Given this list of marker genes PIWIL1, ALOX12, ZFP62, DNAJC17, CSNK1A1, CLCF1, GTPBP2, CYP3A7, F10, NUP133, MAPK9, TMOD3, MITF, NINJ1, STRN3, GAB3, SSBP3, UNC93B1, PRPF38A, GOLPH3L (golgi phosphoprotein 3 like), WASHC1, UQCR10, EDN1, PHB1, ZNF22, SQSTM1, YTHDF2, COX6C, UBA7, MAP3K8, CCL2, POP7, FABP3, FCGR3A, SUGT1, RPL7L1, PDCD5, SNTG2, SYTL1, PA2G4, ACTR6, CHRD, GTF2B, MED6, ADAMTS4, C18orf21, CSPP1, LAP3, COPS6, MCCC2, NRROS, FTSJ3, NIPA2, CCT6A, CPOX, APOBEC1, CARS1, RRAS2, NECTIN3, CRISP2, COG8 (NCBI Gene Id 84342), RBMX, BUD31, ACADL, BLOC1S6 (NCBI Gene Id 26258), NMNAT1, C2CD2L, ITM2A, DIRAS1, UQCRFS1, CIDEA, CLP1, ASNS, MRPL49, GLRX3, PPIL2, DUOXA2, FBXO22, RGS2, FASTKD2, GHITM, SGCB (sarcoglycan beta, NCBI Gene Id 6443), CD81, DHX36, STK4, IL12B, TRAPPC5, RBBP7 (RB binding protein 7, chromatin remodeling factor), SERPINB9, BLOC1S4, HDAC3, CA13, TMEM60, CYTH3, PLCZ1, IL10RA, GADD45B, SLCO3A1, ARGLU1, DNAJC13, ERAP1, MAGI1, TINAG, ATF4, SPTA1, AMN, HTRA1, DUSP2, SBDS, ASB3, RIF1, RGS1, TSPYL1, DBNL, IL10RB, LPO, SPIC, LZTFL1, GTF2F2, CHRNA5, PYCARD, CXCL10, MRPL51 (NCBI Gene Id 51258), LSM10, HMX1, UCP2, CRIM1, SERPINC1, REEP3, SUOX, HDC, KDM5C, OGFR, RWDD4, ZNF24, RPS25, RBMXL1, DDX54, RASL12, ARHGAP17, ZNF334, PACRGL, RAP2C, CELF1, IL2RA, ELOC, ENDOD1, KYAT3 (kynurenine aminotransferase 3), POLH, C19orf25, SLFN12, DYNC1LI1, TLR1, LAD1, CHID1, NDUFV1, GLA, KPNA2, METRNL, CFAP36, NDUFS8, ASB13, EIF2B5, KCTD4, DENND2B, IL15RA, TPD52L2, RMDN3 (NCBI Gene Id 55177), TMEM219, GPATCH2, CD300LF, AKT3, RREB1, SUV39H1, IDNK, RNASE4, TBK1 (TANK binding kinase 1), SFXN2, MTMR2, DTNBP1, ALCAM, C5AR1, IGBP1, CNTN6, APTX, AKR1B1, POLE2, NPHS1 (NCBI Gene Id 8183), LHX6, PURB, BRWD3, HMGB1, CRYBB1, NCK2, NAT2, VRK2, CHAC2, PLIN3, CBLN3, here is a description of the gene set: Human Gene Set: GSE17721_CPG_VS_GARDIQUIMOD_8H_BMDC_UP Genes up-regulated in comparison of dendritic cells (DC) stimulated with CpG DNA (TLR9 agonist) at 8 h versus DC cells stimulated with Gardiquimod (TLR7 agonist) at 8 h. from publication Amit I, Garber M, Chevrier N, Leite AP, Donner Y, Eisenhaure T, Guttman M, Grenier JK, Li W, Zuk O, Schubert LA, Birditt B, Shay T, Goren A, Zhang X, Smith Z, Deering R, McDonald RC, Cabili M, Bernstein BE, Rinn JL, Meissner A, Root DE, Hacohen N, Regev A (PMID 19729616) studied in species Homo sapiens mouse primary BMDCs were stimulated with tlr ligands and gene expression changes were profiled on Affymetrix arrays